Given this list of marker genes PPIH, BLM, DNAJC9, PCNA, KIF11, PTTG1, MCM3 (NCBI Gene Id 4172), MSH2 (NCBI Gene Id 8169), TK1, FOXM1, ZWINT, PCLAF, CASP3, MCM7, UNG, RFC3, MYRF, CDT1, RAD51C, MCM5, PNP, HMGB2, MCM2, DLEU1, POLA1, MAD2L1, MYBL2, SLC29A1, E2F1, DCK, H2AX, MCM6, TFAM, POLD3, CORT (cortistatin), CCNE1, RFC2, TPX2, DHFR, DDX23, RAB27A, CSPG5, BARD1, BTG3, UMPS, RRM1, TMEM106C, TOPBP1, TYMS, CDK1, RPA1 (NCBI Gene Id 6117), NUP214, EZH2, FLAD1 (flavin adenine dinucleotide synthetase 1), NASP, here is a description of the gene set: Cellular genes up-regulated in forskin fibroblasts by expression of CMV EI86 protein off an adenovirus vector. We have previously reported that the immediate early (IE)-86 protein of human cytomegalovirus (HCMV) pushes the cell cycle toward S phase but inhibits cell division. We determined the cellular genes activated by the IE86 protein in permissive human fibroblast cells. A 4-fold or greater increase in the steady-state RNA from many cellular genes that regulate the cell cycle, the enzymes for DNA precursor synthesis, and the initiation of cellular DNA replication was detected by high-density DNA microarray analysis. Northern blot analysis confirmed the DNA microarray data. The viral IE86 protein induced a significant increase in the cellular steady-state RNA level from the B-myb, cyclin E, cdk-2, E2F-1, ribonucleotide reductase 1, ribonucleotide reductase 2, thymidylate synthetase, MCM3, and MCM7 genes, but actin RNA was not affected. Cellular genes regulated by the E2F transcription factors were strongly activated by the IE86 protein. In most cases, the cellular genes induced by the IE86 protein were also induced by HCMV infection. This study demonstrates the global array of cellular genes activated by the IE86 protein that pushes progression of the cell cycle from G0/G1 toward the G1/S transition point. species: Homo sapiens Human Gene Set: SONG_TARGETS_OF_IE86_CMV_PROTEIN from publication Song YJ, Stinski MF (PMID 11867723)